The following is a description of a gene set: species: Homo sapiens Human Gene Set: GOMF_BH_DOMAIN_BINDING Binding to a Bcl-2 homology (BH) protein domain. Bcl-2-related proteins share homology in one to four conserved regions designated the Bcl-2 homology (BH) domains BH1, BH2, BH3 and BH4. These domains contribute at multiple levels to the function of these proteins in cell death and survival. Anti-apoptotic members of the Bcl-2 family have four BH domains (BH1-BH4). Pro-apoptotic members have fewer BH domains., and this is the list of marker genes: IRGM, RACK1, BOK, BAX, BAK1, BCL2, BCL2L1, MCL1